Given this list of marker genes MBTPS2, KDF1, JUP, TRPV3, KRT14, KRT17, CARD14, here is a description of the gene set: Subungual hyperkeratosis A thickening of the stratum corneum in the region beneath the nails. Human Gene Set: HP_SUBUNGUAL_HYPERKERATOSIS species: Homo sapiens